Given this list of marker genes MAP3K14, ALG11, VPS54, TUSC1, POMT1, ZFP2, AHI1, SCN8A, EMP2, TNFSF9, ZNF496, AMIGO2, DCLK2, TTC3, SUMF2, IFT74, TMEM181, GTDC1, FKTN, TERB1, DMXL2, MAPK12, URI1, RYK (receptor like tyrosine kinase), PHF1, PSMA3, SRPK3, PAWR, TUBA4A, RARRES2, ZC2HC1A, GCA, SMYD3, DDX11, FAM241A, PDXP, RGMB, VWA8, RABGEF1, PTK2, CCDC122, TSPYL5, JUNB, FGF6, DOCK6, ATF7IP, NR3C2, MTMR10, MADCAM1, XRCC6, FOXRED2, CFAP96, PTCD3, CSTPP1, ZFP41, HYCC2, KIAA0753, ZNF862, DDHD2, EARS2, PER3, ZNF365, LMO7 (NCBI Gene Id 4008), NFKBID, ANAPC4, PJA2, TMCC2, IFIT1B, SLFN13, C2orf68, TTC21B, PPM1B, CHIC1, DOP1A, INSR, VSTM2B, CYP4F3, ADAM8, PPARGC1B, BAMBI, AEN, ARHGEF12, CDYL2, EXOSC10, DIXDC1, UBXN2A, ZBTB10, STIM2 (stromal interaction molecule 2), NAMPT, MBLAC2, LCOR, SLK, IMPDH2, SEMA5A, PPIP5K1, DNMBP (dynamin binding protein), PPP1R10, CCDC91, NUMA1, IFNLR1, ABCA1, FAM83G, SNRNP200, NAP1L4, DUSP8, FCMR, CD40, PSKH1, FAM135A, ZNF639, PRMT2, DTD2, PBX4, CEP290, RAB3GAP1, CER1, ZNF318, PFKP, KIAA0040, MAST4, BMI1, TMEM63A, CYP4V2, RAP1B, APPL2, RAB20, GPN1, CELF2 (NCBI Gene Id 10659), GAD1 (NCBI Gene Id 50977), HACD4, PARD3B, ZSWIM9, NRF1, ACVR1B, RBM19, GPHN, RAB6B, NXPE4, FRYL, FAM114A1, GTF2IRD2, TRPM2, CCDC82, RUSF1, GART, VPS8, CHST15, FHIP1B, ATPSCKMT, GUCA1B, KMT2E, OSBPL3, HS1BP3, MRTFB, ZNRF1, UBQLN2, EGR3, NEK3, NEAT1, BBS2, ZNF532, DENND2D, DBP, BIRC3, LRRC14, HS3ST1, FHIP1A, DENND3, AFP, PSTK, RFTN2, RDH5 (NCBI Gene Id 81991), PARP16, FARP2, TBC1D5, INTU, ZFP14, ZNF444, PWP2, ATG10, ABCF3, AKAP5, PROX2, POU2F1, DNAAF8, MAP3K2, ST6GALNAC3, KSR1, SNHG12, VWA7, PTPN14, RSRC2, POMGNT1, SYNPO2L, MTAP, NUP58, TANGO2, DNAJA1, TIPARP, ITPR3, here is a description of the gene set: Th1 and Th2 cells arise from a common precursor cell in response to triggering through the TCR and cytokine receptors for IL-12 or IL-4. This leads to activation of complex signaling pathways, which are not known in detail. Disturbances in the balance between type 1 and type 2 responses can lead to certain immune-mediated diseases. Thus, it is important to understand how Th1 and Th2 cells are generated. To clarify the mechanisms as to how IL-12 and IL-4 induce Th1 and Th2 differentiation and how TGF-beta can inhibit this process, we have used oligonucleotide arrays to examine the early polarization of Th1 and Th2 cells in the presence and absence of TGF-beta after 0, 2, 6 and 48 hours of polarization. Human Gene Set: GSE2770_UNTREATED_VS_ACT_CD4_TCELL_6H_DN from publication Lund R, Aittokallio T, Nevalainen O, Lahesmaa R (PMID 14607935) Genes down-regulated in CD4 T cells: untreated (0h) versus activated by anti-CD3 and anti-CD28 (6h). studied in species Homo sapiens